Given this list of marker genes PALS1, CLDN5, MAL, CLDN19, PTEN, ANXA2, JAM3, PRKCI, MAG, SIRT2, MARVELD2, NCMAP, here is a description of the gene set: species: Homo sapiens Regions within compact myelin in which the cytoplasmic faces of the enveloping myelin sheath are not tightly juxtaposed, and include cytoplasm from the cell responsible for making the myelin. Schmidt-Lanterman incisures occur in the compact myelin internode, while lateral loops are analogous structures found in the paranodal region adjacent to the nodes of Ranvier. Human Gene Set: GOCC_SCHMIDT_LANTERMAN_INCISURE